The following is a description of a gene set: studied in species Homo sapiens Abnormal hard palate morphology Human Gene Set: HP_ABNORMAL_HARD_PALATE_MORPHOLOGY, and this is the list of marker genes: RNU4ATAC, KRAS, GNPAT, TBX1, CDT1, PPP2R5D, MAP2K1, B3GALNT2, SHH, AMER1, BICRA, BCOR, PDE11A, STAG2, KAT5, CARS1, PRKAR1B, B4GAT1, KIF7, DGCR2, ORC1, RPS23, DVL1, CUL3, ORC4 (NCBI Gene Id 5000), LARGE1, POMK, FKTN, HYAL1, RXYLT1, LIG4, CDH11, SOX6, GLI2, SNRPB, PRKAR1A, SON, LRP5, HS2ST1, SMCHD1, GMNN, PIEZO2, PTDSS1, ZMPSTE24, RAD21, GDF11, ZBTB20, HAAO, SMAD4, TP63, AMMECR1, MAP2K2, COL2A1, POMGNT1 (protein O-linked mannose N-acetylglucosaminyltransferase 1 (beta 1,2-)), DGCR8, ZEB2, PRR12, SOX9, CRPPA, POMT1, POMT2, CDC6, TCTN3, ESS2, ORC6, FOXP2, DHCR24 (24-dehydrocholesterol reductase), BRAF, DGCR6, SIAH1, WBP11, SIX3, COL4A1, DAG1, HYLS1, CDC45, BMP4, KAT6B, POMGNT2, WNT5A (NCBI Gene Id 7474), LMNA, SET, FKRP, NSUN2